Given this list of marker genes FSTL1, RNF144B, TBC1D25, RPP14, JPT2, TM4SF1, POU1F1, CPED1, UMPS, ETAA1, LMOD2, IQSEC2 (NCBI Gene Id 4382), SLC22A4, AICDA, RALB, ZCCHC4, OPRK1, TSHR, DAPL1, DUT, HOXC8, TGFBI, TAGLN2, DRGX (NCBI Gene Id 648501), CRP, EXOSC9, ITGB3BP (integrin subunit beta 3 binding protein), CREG2, HAT1, LTV1, MAP3K8, LCP2, L2HGDH, TIMM10, SLC22A13, ELOVL4, IRAG2, FAM170B (family with sequence similarity 170 member B), KCNK13, PTPN13, CIDEB, SLC35F3, LSM5, KTI12, CDC26, KIAA1217, NUDT9, ATOH1, RAP1B, MYBPH, PIWIL1, MORN1, SLCO2A1, GRIN2A, ACOXL, LRFN5, ZDBF2, KLRK1, RELT, TUBA1B, LMO2, SPRYD3, NOP10, C9, SAMSN1, TMEM74B, ITK, PLA2G3, RTP3, MRPL21, BID, MZB1, LCAT, UTP18, ADAMTS18, CEACAM20, C1QL3, SEPTIN11, NHSL2 (NHS like 2), ETV4, PMS1, C1orf131, TTC7B, SMS, WWC2, MS4A1, PLXNA3, SLC17A6, IGF2BP2, GRIN1, SET, SMG7, MTM1, NUDT4, SLC25A27, GJC3, BACE1, GART, COPS7B, KLK7, NOP16, L3HYPDH, TAS1R2, PCYOX1L, SLC25A3, LSAMP, RPUSD1, IDO2, HIKESHI, PCDHB6, PRMT8, SRSF10, SLC5A12, C3orf85, SYT6, ZNF219, NDUFA5, EIF4E (NCBI Gene Id 1977), TRIM10, PCSK5, RUNX1T1, DARS1, NIP7, GORASP1, LAP3, INAVA, AKR1D1, HSP90AA1, KRTAP2-4, BHLHE41, ABCA6, CMC2, MLKL, PANX3, PCDH15, MYH1, SPINT1, RYR3, MRPL18, CYP4F12, PIN1, SCRN1, DPT, MED11, CCNB1IP1, GSX2, EIF5A (NCBI Gene Id 1984), BEST2, BAAT, SPHKAP, POGLUT3, LRPPRC, BCCIP (NCBI Gene Id 56647), NEUROD1, LRR1, NABP1, CNPY3, TSPAN12, CFAP161, DBN1, CASS4, RAPGEF1, PDLIM1, MAPK11 (mitogen-activated protein kinase 11), LRAT, APOBEC1, MEGF6, KBTBD12, GNPTG, TNFAIP8, CYFIP2, TM6SF1, EFR3B, FGF1, NHERF4, SARS2, CALHM6, COX16, STK39, FLACC1, THEMIS2, EDEM1, MPHOSPH10, MACROH2A1, CTTNBP2 (cortactin binding protein 2), CDH7, DHFR, CTH, NAT10, TMEM169, SMNDC1, CHPF, EED, SPI1, CD48, SSPOP, NCAM1, RNF222, SMPD3, CD53, here is a description of the gene set: Human Gene Set: GSE3691_IFN_PRODUCING_KILLER_DC_VS_CONVENTIONAL_DC_SPLEEN_DN species: Homo sapiens To characterize differences between BALB/c splenic CD11cintB220+Gr1+ PDCs (plasmacytoid dendritic cells), CD11cintB220+CD49b+ IKDCs (interferon producing killer-dendritic cells), and CD11chighB220- cDCs (conventional dendritic cells), we performed gene expression profile analysis using Affymetrix chips. We FACS-sorted BALB/c spleen DC subpopulations. Comparison of differentially expressed genes between IKDCs and cDCs vividly revealed selective expression of multiple NK-related genes in IKDCs. These included granzymes A, B, K and M, perforin, Fas ligand, and NK receptors such as NKG2A, NKG2D, Ly49 family genes, NKR-P1, NKG7, NKp46 and Mafa (KLRG1). No NK-related genes were highly expressed in the PDCs. Genes down-regulated in dendiritic cells from speen: interferon producing killer cells versus conventional. from publication Chan CW, Crafton E, Fan HN, Flook J, Yoshimura K, Skarica M, Brockstedt D, Dubensky TW, Stins MF, Lanier LL, Pardoll DM, Housseau F (PMID 16444266)